Given this list of marker genes SPOPL, TEAD1, RAB22A, ETV1, MAP3K2, INTS12, CRPPA, MSANTD3-TMEFF1, MAP3K21, LPP, FNDC3B, SSBP2, KCNQ3, DDX19B, VCAN, TMEM220 (transmembrane protein 220), DSCC1, APBB2, LRP6, SEMA3A, LYN, TPMT, NOP2, TMEFF1, RRAS2, TOGARAM1, ABO, MIDEAS, LAMP2, PHF21B, CYP26B1, PBRM1, ZFX, DLK2, NETO1, PIGV, ZNF546, MTPAP, PANX3, TM2D2, C10orf90 (NCBI Gene Id 118611), CEBPZOS, PMS2, TMEM144, AIMP1, SMAD2, CLCC1, ZFPM2, TMEM209, LRRFIP1, WWOX, WDR33, ACSL4, TAOK1, CYP3A4, RABL3, RANBP10, CNTNAP5, CAPN6 (NCBI Gene Id 827), JCAD, PNMA8B, ZZZ3, ENTPD1, SETD9, CACNB1, CCDC191, ERAP1, SERTAD2, ZBTB20, FGF7, EGR3, ROCK2, ADAM23 (ADAM metallopeptidase domain 23), FAM120C, VPS13C, ULK1, RGS7BP, HSPA1A, ZC3H12B, NEURL1B, OLAH, DYNLRB2, TSPAN2, PAX6 (paired box 6), AMACR, DIDO1, LRRC31, SLC24A2, RPS6KA3, ARMC8, ALDH3A2, NHSL1, FRMD3, SP3, PLAG1, PMP2, RAD54B, PEAK1 (pseudopodium enriched atypical kinase 1), FSBP, GLT6D1, TBL1XR1, ZBTB10, ZNF493, ZSWIM1, ARID4B, SLC2A1, ABHD17B, SNX16, WDR41, CHAC2, UGT3A1, YPEL2, GRIA3, RHOBTB3, RAB14, NUP58, KLF5, ZNF441, COL6A6, EFNB2, KANSL1L, PDXDC1, TRIM5, DIP2B, SRI, ATP2C1, MSL3 (MSL complex subunit 3), GTPBP2, UBE2V2, DEFB110, DENR, THUMPD3, ALDH1L2, FYB1, USP25, NXT1, DEK, ZNF99, DESI2, MACC1, SLC44A1, TRAPPC10, SEC23IP, HMCN1, FUZ, ATP6V1B2, ARF6, YWHAQ, ADAMTS5, PATJ, PCDH11Y, SPRY2, SPACA1, DGKH, CHIC1, LRRC59, XRCC5, GABRA6, OSBPL9, NETO2, here is a description of the gene set: Genes predicted to be targets of miRBase v22 microRNA hsa-miR-223-5p in miRDB v6.0 with MirTarget v4 prediction scores > 80 (high confidence targets). studied in species Homo sapiens Human Gene Set: MIR223_5P from publication Chen Y, Wang X (PMID 31504780)